The following is a description of a gene set: Any process that modulates the rate, frequency or extent of membrane depolarization. Membrane depolarization is the process in which membrane potential changes in the depolarizing direction from the resting potential, usually from negative to positive. Mouse Gene Set: GOBP_REGULATION_OF_MEMBRANE_DEPOLARIZATION studied in species Mus musculus, and this is the list of marker genes: Cck, Hsh2d, Cacna1c, Cacna1g, Bok, Hcn4, Ngfr, Nedd4l, Trpm4, Tbx5, Slmap, Gja1, Lrrk2, Cacna1d (calcium channel, voltage-dependent, L type, alpha 1D subunit), Clcn2, Abcd1, Oga, Adcy10, Fzd9 (NCBI Gene Id 14371), Smad7, Alb, Scn3b, Scn2b, Gclm, Mllt11, Ntsr1, Fhl1, Fgf12, B2m, Alox12, Parp1, Gclc, Got1, Ptpn3, Cav3, Myoc, Rack1, P2rx7, Hcn2, Tspo, Ank3, Gja5, Rangrf, Hcn3, Kdr, Ppp2r3c, Cftr, Scn5a, Creb1, Camk2d, Dcn, Src, Hcn1, Rbfox2, Gpd1l, Scn1b, Scn10a, Npff